The following is a description of a gene set: Human Gene Set: HP_ACUTE_RHABDOMYOLYSIS Acute rhabdomyolysis An acute form of rhabdomyolysis. studied in species Homo sapiens, and this is the list of marker genes: TANGO2, CTDP1, CACNA1S, LPIN1, RYR1